The following is a description of a gene set: Human Gene Set: MIR7114_3P Genes predicted to be targets of miRBase v22 microRNA hsa-miR-7114-3p in miRDB v6.0 with MirTarget v4 prediction scores > 80 (high confidence targets). studied in species Homo sapiens from publication Chen Y, Wang X (PMID 31504780), and this is the list of marker genes: GAB2, SEMA3C (semaphorin 3C), ZNF850, ITPRIPL2, TUBAL3, EPM2A (NCBI Gene Id 7957), TMEM121B, IQGAP3, RBFOX1 (RNA binding fox-1 homolog 1), C10orf90, PHC3, TM9SF3, MMP16, RCAN2, TEAD3, ACER3, PDXDC1, MARCHF9, DDX20, ZC3H12D, LRRC8A, HEXIM1, DISC1, SNU13, SHPK, SCUBE3, MIA2, NPNT, ZC3H12A, BET1L, CCP110, ZNF641, SPOPL, AMMECR1, DNAJB1, CASQ1, CCNE1, NINL, SPSB1, DCAF10, PDE11A, TXLNA, EPCIP, RNF38, HSPB7, FAM170B